The following is a description of a gene set: Genes down-regulated in T conv: peripheral lymph nodes versus thymic CD24 high. species: Homo sapiens Human Gene Set: GSE42021_TCONV_PLN_VS_CD24HI_TCONV_THYMUS_DN We investigated at which stage of maturation commitment to a stable Foxp3-expressing phenotype takes place. We assessed stability of Foxp3 expression in thymic Foxp3+ Treg subsets of different maturity, defined by CD24 expression. Next we compared gene expression profiles of Foxp3+ Treg subsets (+) of different maturity (24lo, 24int, 24hi) and could identify a set of genes that were specifically up or downregulated in Foxp3+ Tregs, but not in Foxp3- conventional T cells, in a maturation-dependent manner. from publication Toker A, Engelbert D, Garg G, Polansky JK, Floess S, Miyao T, Baron U, Düber S, Geffers R, Giehr P, Schallenberg S, Kretschmer K, Olek S, Walter J, Weiss S, Hori S, Hamann A, Huehn J (PMID 23420886), and this is the list of marker genes: PDIA2, PNMA8A, EML1, OAS2, MB, FUZ, ROR1, NMB, BCAS4, MPP2, APMAP, SYBU, AP1M2, TPCN1, APOBEC3B, ANXA6, ATP6V1H, LY6E, COIL, RIGI, RAD51, CAVIN1, MYO5C, GTF3C1, ELOVL6, GNB5, RAP1GAP, AQP3, KRT19, UNC93A, NRCAM, CEP72, GPC1, HOXA10, FANCI, LAMP3, CUL4B, ASF1B, PIK3CB, LIN28A, CALU, MGLL, GYG2, SYNM, BCR, ISG15, COL21A1, HERC6, DNAJB9, JAG2, FAM114A1, MYD88, LSS, GPRC5A, PRORP, KCNG2, IFNA6, ENO2, DLG1, PRKCH, KANK2, IFI27, OAS3, GPRC5B, FBN2, HJURP, HTRA1, EPB41L4B, PALLD, RABAC1, MYH10, TGFB1I1, SMARCA2, ZNF185, MEGF9, ESPL1, OASL, KIFBP, SORT1, CERK, IFI44L (NCBI Gene Id 10964), TRIM14, MAN2B2, IRF7, CA12, RAB40B, PSORS1C2, PBX3, MAEA, MISP, MARCKS (myristoylated alanine rich protein kinase C substrate), GAL3ST1, CUTA, MX1, SDC1, UCP2, AICDA, PDXDC1, RPA1, SLC3A1, MMP24, SMAGP, SYNGR3, PRSS23, CRELD2, IGSF3, KDM8, CAP2, GTSE1, MX2, SSTR1, RPS6KA4, RS1, IFIT1, DEPTOR, JUP, IFI6, H2BC11, ECM2, EMP3, HSPA12A, PCSK5, ATP5PF, DDX24, ABCC5, PAAF1, EBP, PCOLCE2, PYY, UNC119B, BRME1, AHCYL1, KIAA0232, EPB41L1, DPY19L1, USP18, HERC5, CD9, FAM131A, ANK3, EMC9, LRRC19, IFI44, C1orf116, CTDSPL, SERPINE2, H1-5, LASP1, ZNF768, CREB3L2, SLCO2B1, NKX6-1, CUL9, NDRG1, CDHR1, DEXI, MALL, CD2BP2, UNC13A, SPINT2, NIPSNAP1, CNPPD1, GNB1, NACC2, B4GALT4, HOMER3, TUBA1A, DHCR7, SCARA3, HSPA2, GM2A, ABCD3, OAS1, ANKRD2, SOX9, NAE1, CASK, GMFB, TDRD7, GABRR2, RTN2, SLC25A10, GTF2H5, CLSTN1, ADAMTSL3, PPL, COPS8 (COP9 signalosome subunit 8), HS1BP3, BEGAIN, RHOD, KCNJ9, EXT1, PIGG, GALNT7, RBM4B, ADGRG2, YIF1B, FOXA1, LRP4